Given this list of marker genes DIO2, DIO1, DIO3, here is a description of the gene set: studied in species Homo sapiens Production and secretion of the thyroid hormone T3 and its inactive precursor T4 by thyroid follicular cells is regulated by Thyroid-stimulating hormone (TSH, thyrotropin) signalling and several feedback loops involving iodine and thyroglobulin. Reactome Pathway: Regulation of thyroid hormone activity part of: Thyroxine biosynthesis